Given this list of marker genes ANAPC7, CREB3L3, PNRC1, SOX5, STRN, HIPK1 (homeodomain interacting protein kinase 1), NDST3, TBCD, SUSD2, RHOBTB1, DCBLD2, ZSWIM6, CARHSP1, KCNJ14, TWNK, PTPRE, MEN1, ALPK3, EPX, HOXA5, TNRC6C, TGFBR3, TOPBP1, SLC20A2, PDGFA, HOXA11, PTGER4, SVOP, JADE2 (NCBI Gene Id 23338), QTRT2, KIAA1549, MCTP1, XPO4, EFNA5, VKORC1, IGBP1, EME1, SNN, NFATC4, MGAT5, CSF1, BSDC1, BTG4, SPDYA, WFS1, ACVR1B, MAGI1, SERTAD1, FGF1, HIVEP2, MAP2, DAG1, JPT1, CSRNP2, HLA-DOB, AVL9, CPLX3, TNFSF9, TSGA10, HK2, RAB30, EFR3B, ABCB10, TNR, ADGRE2, TRAT1, MYCBP2, TOR3A, CYB5B, RETREG1, LZTS3, PKNOX1, CDK9, CCR9, MFSD14A, ZMIZ1, PIKFYVE, REV1, DPYSL2, TGM2, IFNAR1, NDOR1, SORBS1, COLQ, IL21R, HNRNPR, MED8, here is a description of the gene set: studied in species Homo sapiens from publication Chen Y, Wang X (PMID 31504780) Human Gene Set: MIR484 Genes predicted to be targets of miRBase v22 microRNA hsa-miR-484 in miRDB v6.0 with MirTarget v4 prediction scores > 80 (high confidence targets).